Given this list of marker genes Scarb1, Stra6, Slc5a6, Slc46a1, Stra6l, Slc19a3, Slc19a2, Slc27a1, Selenon, Slc25a32, Gc, Slc44a4, Slc22a2, Rbp4, Slc23a2, Slc19a1, Slc25a19, Lrp2 (NCBI Gene Id 99378), Slc22a1, Slc23a1, Abcc5, Slc47a1, here is a description of the gene set: studied in species Mus musculus Mouse Gene Set: GOBP_VITAMIN_TRANSMEMBRANE_TRANSPORT The process in which a vitamin is transported across a membrane. A vitamin is one of a number of unrelated organic substances that occur in many foods in small amounts and that are necessary in trace amounts for the normal metabolic functioning of the body.